The following is a description of a gene set: from publication Costello P, Nicolas R, Willoughby J, Wasylyk B, Nordheim A, Treisman R (PMID 20554967) studied in species Homo sapiens Genes up-regulated in double positive thymocytes stimulated by anti-CD3: wildtype versus ELK1 and ELK4 knockout. Removal of the transcription factor SAP1a member of the Ternary Complex Factor (TCF) group of transcription factors which in conjunction with Serum Response Factor (SRF) has been shown to have a profound effect on positive selection in the thymus. When another TCF Elk1 is knocked out in mice there is no effect on positive selection unless it is on a Sap1a KO background where the phenotype is very severe. We have stimulated isolated double positive T cells (DPs) with anti-CD3 to mimic positive selection and compared basal and stimulated transcription across the four genotypes to discover the downstream targets of Sap1a involved in positive selection. Human Gene Set: GSE21546_WT_VS_SAP1A_KO_AND_ELK1_KO_ANTI_CD3_STIM_DP_THYMOCYTES_UP, and this is the list of marker genes: TRAPPC2, EHD3, RASD1, LMOD1, ZNF540, PRKACB, HDC, EXOC1, RALB, SPIN1, CCNG2, ZNF703, ATRN, RAB39B, LINC02458, ZCCHC12, KRT18, NCOA7, VAT1L, CLIP1, MGST3, ACTG2, ZNF641, NREP (NCBI Gene Id 9315), OFCC1, SSTR2, TTC8, MIR137HG, SYT17, PRKCH, FAM13B, IGFBP6, ATAD1, ZNF177, TRAPPC8 (NCBI Gene Id 373175), KDM5B, DYNC1I2, LINC00654, PCDHB10, MPDZ, ARL6IP5, RAB27B, CLASP2, NAP1L2, EDA, CFI, NEDD9 (NCBI Gene Id 4739), MMD, ITPRIPL2 (ITPRIP like 2), TBCK, CPVL-AS2, AIG1, TMEM140, CYLD, ZNF711, SNX30, GDPD1, HYI, HOXD11, RAB2A, PLAT, DNAJB6, HOXD10, WARS1, SYT1, SPRY1, TSC22D1, GPRASP2, RAB6B (RAB6B, member RAS oncogene family), CYB5R1, PGM2L1, CALCB, AKAP6, CTTNBP2NL, MYADM (NCBI Gene Id 91663), ZNF25, DDC, FSTL1, SNX16, ZNF664 (NCBI Gene Id 7729), CADPS, TMED10, DUSP1, CREM, PELO, CLIP4, FOXC1, FGD6, CPAMD8, LCP1, KLF3-AS1, MANBA, DYNLRB1, BEX4, TPRG1L, GPNMB, IFI16, GSDME, RND3, NAPB, BTG2, GRB2, SMDT1, KIFAP3, SCYL2, ITGB1, SMAGP, COL1A1, FSD1L, CCNDBP1, MTMR9, FIG4, SAMD9L, KIF5A, BNIP3L, SOCS6, LSAMP, COX20, TAGLN3, LRRN3, FSTL3, TMEM30A, FREM1, RTN1, XYLT1, H2AC6, PSEN1, LINC00622, APC, LINC02381, OLFML3, TAGLN, CYP3A5, PTPRH, SMARCA1, LTBP1, SUOX, OTUD1, PCDHB14, ARSA, BMPR2, OPTN, CLK1, OSBPL10, SERINC1, CEBPD, CMAHP, ADD3, VCL, SWT1 (NCBI Gene Id 54823), ABCB1, ZNF155, MYH9, PICALM (phosphatidylinositol binding clathrin assembly protein), MYL12B, ITFG1, PDP1, RASA1, RUFY3, HBP1, SMIM3, TSPAN7, LINC01587, KIDINS220, ZNF627, OSTF1, ATP9A, EXD2, DKK2, TUG1, H3C6, KCNN4, BEX1, CEMIP2, ZNF793 (NCBI Gene Id 390927), WDR47, PLPP6, HOXD1 (homeobox D1), PRSS16, MAGEH1, VPS13D, HSPB8, TMEM238L, CDRT4, CYP26A1, FRAT1, NAP1L3, PIK3R1, ADAM19, NUDT9P1, AMN1, CCDC68, IFT70B, NCOA4, REEP1, PTPN21, AHR, CCNA1